Given this list of marker genes Irf3, Irf7, here is a description of the gene set: part of: Toll Like Receptor 3 (TLR3) Cascade This event has been computationally inferred from an event that has been demonstrated in another species.<p>The inference is based on the homology mapping from PANTHER. Briefly, reactions for which all involved PhysicalEntities (in input, output and catalyst) have a mapped orthologue/paralogue (for complexes at least 75% of components must have a mapping) are inferred to the other species. electronically inferred by orthology from the curated human pathway Reactome Pathway: TICAM1-dependent activation of IRF3/IRF7 studied in species Mus musculus